The following is a description of a gene set: studied in species Mus musculus from publication Iwanaga K, Yang Y, Raso MG, Ma L, Hanna AE, Thilaganathan N, Moghaddam S, Evans CM, Li H, Cai WW, Sato M, Minna JD, Wu H, Creighton CJ, Demayo FJ, Wistuba II, Kurie JM (PMID 18281487) Phosphatase and tensin homologue deleted from chromosome 10 (Pten) is expressed aberrantly in non-small cell lung cancer cells, but the role of Pten in lung neoplasia has not been fully elucidated. In this study, we used a genetic approach to inactivate Pten in the bronchial epithelium of mice. Although, by itself, Pten inactivation had no discernible effect on bronchial epithelial histology, it accelerated lung tumorigenesis initiated by oncogenic K-ras, causing more rapid lethality than that induced by oncogenic K-ras alone (8 weeks versus 24 weeks of median duration of survival, respectively). Lung tumors arose in K-ras mutant, Pten-deficient mice that rapidly obstructed bronchial lumina and replaced alveolar spaces. Relative to K-ras mutant tumors, the K-ras mutant, Pten-deficient tumors exhibited more advanced histologic severity and more prominent inflammation and vascularity. Thus, Pten inactivation cooperated with oncogenic K-ras in promoting lung tumorigenesis. Cluster 3: genes up-regulated in lung tissue samples from mice with tumor-bearing genotypes (activated KRAS alone or together with inactivated PTEN). Mouse Gene Set: IWANAGA_CARCINOGENESIS_BY_KRAS_UP, and this is the list of marker genes: Egfl6, Asph, Creb3l1, Ube2q2l, Eps8l1, 4930447A16Rik, Slc45a4, Bod1l, Fbn2, Gpr27, Gosr1 (golgi SNAP receptor complex member 1), Dnah8 (NCBI Gene Id 268939), Brdt, Scd1, Acbd5, Epcam, Fam83g (NCBI Gene Id 69640), Trappc2b, Gja1, Ppp2r5c, Mrc2, Zfp39, Tgoln1, Atp1a1, Ldha, Dnajc12, Galnt3, Ctsz, Mcoln3, Inip (NCBI Gene Id 67176), Cdkl5, Elf5, Rai14, Cygb, Coa8, Ankrd48, Pomgnt1, Kcnj15, Lrg1, Dnm2, Schip1, Atrx (NCBI Gene Id 67403), Dusp15, Cks1b, Nrcam, Slc15a2, Pnn, B3gat1, St14, Lgr6, Ctps1, Osgin2, Soat1, B4galnt1 (beta-1,4-N-acetyl-galactosaminyl transferase 1), Clu, Mtus1, Ecm2, Cntn6, Crebbp, H2-Q2, Ckmt1, Cd55, Wnt5b, Chia1, Ipo8, Bcl9l (NCBI Gene Id 80288), G2e3 (G2/M-phase specific E3 ubiquitin ligase), Tedc2, Fam185a, Scp2, Nipa1, Me1, Nptxr, Kdf1, Serpinb12, Fam120a, Fam3c, Puf60, Asb9, Dennd5b, Supt7l, Ift43, Tcim, Ackr4, Ptgir, Sptlc3, Epha1, Ldhd, Mtmr1, Hoxd8, Pex7, Sox2, Bend4, Prnp, Ferd3l, Pcdhb16, Csnk1a1, Rad51ap1 (RAD51 associated protein 1), Ncs1, Fam234b, Hnf1a, Glrx, Derl2, Mal, Magi3, Gde1, Tekt5, Tfcp2l1, Pafah1b3, Tgfbr2, 5430405H02Rik, Tenm2, Ibsp, Smarca5, Commd3, Camta1, Iapp, Dhcr7, Igf1, Cldn12, Epha5, F7, Stk38, A830082K12Rik, Pdcd2, Gpbp1l1, Slc9b1, Scrg1, Rnf123, Cdc40, Zfp563 (NCBI Gene Id 328799), Dusp21, Zfp773, AI606473, D930048N14Rik, Rnf13, Wbp1, Peli1, Hnmt, Ppp1r14c, Uqcc4, Gabrb3, Sdc1, Uri1, Emx2, Cxcl5, Chrac1, Ereg, Nrxn3, Tada1, Arg2, Gm6600 (predicted gene 6600), Aebp2, Eif4g3, Snx30, Spint1, Hipk3, Ttn, Glcci1, Adam26a, Slc43a2, Adcy7, 2510017J16Rik, Fuca2, Ifngr2, Zfp598, Ptgr2, Adk, Rnf181, Vps35l, Emb, Ctsh, Pcx, Rnf225, Znrf1, Runx1 (runt related transcription factor 1), Gimap6, Ldlr, Slc16a1, Tsen54, 4933406B17Rik, Wdr91, 1810014B01Rik, Atp6v1c1